The following is a description of a gene set: Human Gene Set: GNF2_NS Neighborhood of NS NULL in the GNF2 expression compendium species: Homo sapiens Neighborhood of NS, and this is the list of marker genes: IMPDH2, GNL3, MTREX (Mtr4 exosome RNA helicase), OLA1, PSMA4, PAICS, CCT8, HNRNPA2B1, SNRPD2, RAN, MSH6, ADSL, CCT4, GTPBP4, MTHFD2, IARS1, ATIC, MRPS33, ABCE1, SSBP1, PRKDC, MRPL3, TAF1D, PSMA5, HMGN1 (high mobility group nucleosome binding domain 1), MRPS27 (mitochondrial ribosomal protein S27), SNRPE, EPRS1, C1QBP, NPM1, PSMA2, PARP1, LRPPRC, HSPA9, RSL24D1, GLO1, SNRPF, PSMA3, CCNG1, CCT3